Given this list of marker genes PCP2, YY1, AQP1, FBXW7, CUL4B, STK11, CERS1, NLRP1, OPN5, DDB2, RUVBL2, RHNO1, AIPL1, CASP9, RGS9, CRY1, BAX, RRH, RP1, CDKN1A, PARP1, KDM1A, INO80, MFAP4, OPN4, SIRT1, METTL3, DDB1, OPN3, HYAL1, TP53 (tumor protein p53), NSMCE3, H2AC25, PCNA, SMPD1, PIK3R1, MDM2, ACTR5, BMF, CUL4A, SAG, XPC, USP28, GUCY2F, NMT1, BAK1, POLK, CAMKMT, EIF2AK4, GPR52, MYC, MMP9 (matrix metallopeptidase 9), OPN1MW3, TMEM161A, SDE2, PBK, TREX1, EP300, MAP3K20, RBX1, MME (NCBI Gene Id 4311), PIERCE1, RPL26, MC1R, POLD3, TIMP1 (TIMP metallopeptidase inhibitor 1), SLC24A4, NMT2, CRY2, ATR, POLA1, NPM1, MMP1, NOC2L, MAPK14, HYAL3, PPID, N4BP1, MAPK13, NFATC4, CREBBP, POLH, PRKCD, COPS9, GNB5 (G protein subunit beta 5), GRK4, ATF4, GUCY2D, RHO, AURKB, MMP2, EIF2S1, NEDD4, MMP3, OPN1MW, OPN1MW2, DHX36, OPN1LW, TRPM1, ZBTB1, RGR, TAF1, TRIAP1, ERCC4, RHBDD1, EI24 (EI24 autophagy associated transmembrane protein), AKT2, OPN1SW, PTPRK, GRK7, ERCC1, ST20, TP53INP1, CRB1, SLC24A2, CRIP1, GNAT1, HYAL2, GRK1, MAPK11, GPR88 (NCBI Gene Id 54112), XPA, POLD1, here is a description of the gene set: Any process that results in a change in state or activity of a cell (in terms of movement, secretion, enzyme production, gene expression, etc.) as a result of a light stimulus, electromagnetic radiation of wavelengths classified as infrared, visible or ultraviolet light. studied in species Homo sapiens Human Gene Set: GOBP_CELLULAR_RESPONSE_TO_LIGHT_STIMULUS